The following is a description of a gene set: Mouse Gene Set: GOBP_POSITIVE_REGULATION_OF_CELL_DIFFERENTIATION studied in species Mus musculus Any process that activates or increases the frequency, rate or extent of cell differentiation., and this is the list of marker genes: Cxcr4, Sox6, Tgif2, Kat7, Mdk, Akap6 (A kinase anchor protein 6), Dcstamp, Spi1, Bmpr1b, Rhoh, Lrp8, Ppp1cc, Pla2g3, Sox12, Smarcd3, Epc1, Rab21, Hoxa5, Myocd, Gli3, Rarres2, Crabp2, Il20, Sash3, Smarca4, Acvr1b, Il6st, Ranbp3l, Tnfrsf11a, Il2, Alx1, Actr3, Smyd1, Agtr1b, Plcb1, Ninj1, Pdlim7, Twist1, Sav1, Proc, Cdkl3, Stat5b, Inhba, Nap1l1, Golga4, Nog, Sfrp4, Ep300, Fezf1, Eng, Camk2b, Jund, Isg15, Mustn1, Sh3pxd2b, Ntn1, Alox8, Epha4, Numbl, Gh, Mturn, Lck, Foxc1, Spdef, Ifitm1, Tnfrsf12a, Pithd1, Stk25, Fzd1, Clic1, Id2, Glul, Phf10 (PHD finger protein 10), Brinp1, Dlk1, Prkd1, Itpka, Eif5a, Rpl4, Hoxa11, Neurl1a, Yap1, Akt1, Il36b, Gli2, Tshz3, Il5, Il2rg, Tnf, Ctnnbip1, Tacstd2, Ccl19, Cbfb, Cebpa, Emp2, Ap3d1, Cyb5d2, Mir124a-1, Mdm2, Bcl2, Sema5a, Asxl2, Eif2b2, Tfe3, Zfp36l1, Parp2, Cth, Grip2, Otp, Macf1 (NCBI Gene Id 97195), Skil, Wdr62, Gdf7, Trp73, Prkca, Vwc2l, Cpne1, Drd2, Zfp335, Ptch2, Nedd9, Fam20c (NCBI Gene Id 97210), Apc, Msx2, Etv5, Lamb1 (laminin B1), Myrf, Tbx5, Bmal1, Zfp365, Sema4d, Asb4, Sart1, Fermt2, Ankrd54, Cysltr1, Gfi1, Cebpd, Islr2, Faim, Sirt2, Ncoa1, Ifng, Mfn2, Gper1, Map1b, Dkkl1, Kit, Prkcz, Cd1d1, Hcls1, Il2ra, Hif1an, Hap1, Brinp3, Atoh1, Sfn, Dab1, Cd36, Inpp5d (NCBI Gene Id 98312), Eeig1, Mir326, Rela, Il4i1, Dlx1, Glp1r, Kdm1a, Igf1, H2-Ea, Adig, Lilrb4a, Cldn5, Sox10, Cdh4, Tnfrsf1b, Ilk, Mtch2, Rassf10, Foxa1, L1cam, Dcx, Vim, Nrdc, Lmo3, Brinp2, Xrcc2, Il10, Lamb2, Robo1, Dmd, Tgfbr1, Rab7b, Sfrp1, Khdc3, Cd101, Il18, Mcub, Smarce1, Ihh, Smad1, Robo2, Stat1, Gjc2, Mir23a (NCBI Gene Id 387216), Tgfb1i1, Cyfip1, Tlr2, Fndc3b, Ppargc1b, Wnt3, Wnt3a, Aamdc, Ccr7, Pim1, Pa2g4 (proliferation-associated 2G4), Notch4, Sox2, Mad2l2, Prkdc, Hmgb2, Jun, Atraid, Smo, Gfi1b, Map3k13, Vnn1, Sin3a, Tmprss12, Fxr2, Pafah1b1, Foxp3, Rcor1, Gata5, Dmbt1, Arhgap32, Lhx1, Gdf3 (growth differentiation factor 3), Jade2, Kitl, Zbtb7b, Egr2, Socs5, Ikzf1, Dab2, Trf, Dpf3, Adrb1, Ceacam1, Ripk2, Brd4, Il23a, Cdh5, Atxn1, Mapk9 (NCBI Gene Id 26420), Abcb10, Metrn, Rbm4, Mapk8, Arhgef2, H2-M3, Men1 (multiple endocrine neoplasia 1), Arrb2, Adra2b, Sod2, Tlr9, Six1, Gas6, Myf5, Mtor, Gata1, Fzd3, Fbxo31, Shb (NCBI Gene Id 230126), Kdr, Ccr1, Klhl25, Egr3, Map2k2, Zfp385a, Ist1, Mesp1, Btn2a2, Pde5a, Bad, Pten, Snai2, Smad4, Cx3cl1, Cthrc1, Obsl1, Pak3, Syap1, Ezh2, Scin, Bmp4, Dbnl, Macroh2a2, Ovol2, Anxa1, Bdnf, Wnt5a, Mfn1, Klf10, Ripk1, Med1, Ahi1, Nkx2-2os, Dlx5, Olfm1, Sh3gl3 (NCBI Gene Id 20408), Tgfb2, Wwtr1, Faxdc2, Rap1a, Flt3l, Stau2, Tnfsf14, Hamp2, Ntf3, Dixdc1 (NCBI Gene Id 75356), Col1a1, Cyp26b1, Irf1, Wls (wntless WNT ligand secretion mediator), Rfx3, Ltbp3 (latent transforming growth factor beta binding protein 3), Zbtb46, Pou4f2, Dlg4, Tert, Enpp2, Prkci, Rtn4, Zc4h2, Mir100, Fxn, Gdpd2, Carmil2, Tarbp2, Cds1, Neurog1, Rb1, Uchl3, Akirin1, Mylk3, Mecp2, Xkr8, Klf5, Lrg1, Trak1 (NCBI Gene Id 67095), Cd74, Spint1, Adipoq, Cux2, Hopx, Atp11a, Lrp3, Fbn2, Plag1, Fndc5, Fgfr1, Clec7a, Acvr1, Hlx, Morf4l2, Gdnf, Egfr, Trpm4, Mef2c, Ptger4, Gata2, Efna5, Efnb2, Trpc5, Kat8, Fxr1, Crebl2, Ambra1, Smarcc1, Trem2 (NCBI Gene Id 83433), Kctd11, Pcid2, Pou4f1, Rgcc, Cul7, Ptprd, Lrp5, Trp63, Tcf15, Ppp2r3c (NCBI Gene Id 80481), Smad7, Tgfb1, Csf3, Adamts9, Tbx1, Mmd2, Sox4, Edn3, Rnd2, Nap1l2, Ccr2, Carm1, Rest, Cdx2, S100b, Gdf5, Cask, Fgf2, Pdpn, Trib1, Bmpr2, Neurod4 (NCBI Gene Id 11923), Myb, Sfrp2, Cav3, Trpc6, Numb, Xrcc6, Foxa2, Ccn3, Serpine1, Cip2a, Msr1, Kdm4c, Myod1, Dscam, Tespa1, Cmklr1, Sox8, Mapk14, Baiap2, Actl6a (NCBI Gene Id 99742), Serpinf1, Ccne1, Por, Ascl1, Slc25a4, Tox, Bin1, Actl6b, Stk3, Lig4, Insm1, Il1b, Htr2a, Sdcbp, Tescl, Gsx2, Opa1, Ltf, Hsp90aa1, Akap5, Tcf3, Thrb, Zfp219, Fos, Lamc1, Casp8, Ddx39b, Npnt, Tmsb4x, Ccn6, Hnrnpu (heterogeneous nuclear ribonucleoprotein U), Pkdcc, Prdm16, Agt, Hes1, Sp7, Zfhx3, Stk11, Amigo1, Mup20, Lin28a, Adcy10, Cux1, Dusp10, Brd2, Sh3glb1, Dbn1, Tyrobp, Ngfr, Nkx6-2, Vstm2a, Flt1, Neurog2, Runx2, Ror2, Fgfr3, Hoxd3, Ntrk3, Gja1, Xbp1 (NCBI Gene Id 52219), Adnp, Hmgb1, Pias2, Abcb1a, Mag, Slitrk1, Ffar4, Rbm24, Dicer1, Zeb1, Bloc1s5, Ptn, Notch2, Ccn5, Mapt, Nr2c2, Ccr5, Creb1, Slc6a6, Gpr68 (NCBI Gene Id 238377), Cdon, Zbtb7c, Syk, Ptgs2, Nfkbid, Dlx2, Sall1, Dag1, Car2, Caprin2, Hdac1, Xrcc4, Rin2, Gimap3, Dnmt3b, Dll3, Aspa, Piezo1, Scube2, Hoxd11, Duoxa1, Disc1, Vegfc, Bmpr1a, Fdps, Socs3, Impact, Adm, Ret, Hamp, Rnf112, Parp1, Rgs6, Actn3, Atp11c, Ache, Reln, Ncoa3, Rgs14, Foxa3, Aspm, Acvrl1, Wnt9a, Zfp609, Ankrd27, Nppc, Afdn, Zfyve27, Apoe, Mir219a-1, Nbl1, Qki, Lmna, Sult1e1 (sulfotransferase family 1E, member 1), Trip10, Kat2a, Dact1, Pik3r6, Rara, Malt1, Wnt10b, Skint1, Ngf, Lef1, Ocstamp, Bex1, Tcf4, Shoc2, Bcl6, Star, Fes (NCBI Gene Id 14159), Gsk3b, Lama2, Add1, Gdf2, Pax4, Bcl9l, Akap11, Prmt3, Epo, Mir34a, Tspo, Wif1, Il34, Il33, Slc9b2, Prkg2, Itgb3, Ephb2, Fzd4, Etv4, Gcnt2, Cebpb (NCBI Gene Id 18031), Metrnl, Dhx36, Hif1a, Ntrk2, Jag1, Atoh8, Scube3, Cdkn2b, Btg1, Slc7a5, Parp6, Clcn2, Jak2, Dnm1l, Ptprc, Nid1, Tbx20, Nkx6-1, Pin1, Lpl, Tgfbr2, Vsir, Csrp3, Itgam, Limk1, Mir124a-2, Mmp14, Timp2, Vdr, Map2k1, E2f1, Mir223, Hey1, Bmp2, Itgb1, Aurka, Ppp1r13l, Smarcc2, Nin, Tgm2 (transglutaminase 2, C polypeptide), Crb2, F11r, Ss18l1, Sox17, Rufy3, Ptpra, Snai1, Nlrp3, Cxcl9, Tnfsf9, Nkap, Xlr3b, Neurod1, Zc3h12a, Gpc1, Nr3c1, Tent5a, Cyld, Prkch, Runx1, Il21, Ap3b1 (adaptor-related protein complex 3, beta 1 subunit), Sox9, Kat5 (K(lysine) acetyltransferase 5), Trpv2, Arid1a, Grm5, Foxn1, Nkx2-5, Hsf1, Btc, Dkk1, Smap1, Boc, Socs2, Ell3, Heyl, Serpine2, Stat5a, Csf1r, Fbxo5, Shank3, Zbtb1, Prpf19, Lrp2, Ets1, Ifi204, H2-Aa, Gdf10, Ddr2, Nell1, Pparg, Tgif1, Fezf2, Bmp7, Wnt2 (wingless-type MMTV integration site family, member 2), Sox5, Lpar3, Cd34, Chodl, Lrp1, Srrt, Nme2 (NCBI Gene Id 18103), Upf3b (NCBI Gene Id 68134), Shox2, Plxnb2, Clcf1, Prl2c2, Synj1, Myf6, Hspa1b, Csf1, Dubr (NCBI Gene Id 68190), Spen, Cd27, Smad2, Actb, Dpf1, Zbtb16, Ccdc3, Tesc, Sirt6, Dmrta2, Slc30a1, Zfp36, Zhx3, Igfbp3, Lrrc8a, Vwc2, Vezf1, Lama1, Eif4g2, Ada, Plxnd1, Srf, Brd7, Fmr1, Nr5a2, Id4, Csf2, Commd5, Notch1, Ace, Ect2, Cd83, Evi2, Bag1, Ager, Xrcc5 (X-ray repair complementing defective repair in Chinese hamster cells 5), Ctnnb1, Nek5, Noct, Cftr, Ar, Itpkb, Pbrm1, Ccl3, Tnik, Actr2, Pwp1, H2-DMa, Tenm4, Irx3, Smad3, Bend6, Il15, Agtr1a, Sult2b1, Mapk8ip3, Tnfsf4, Nkx2-2, Ccl5, Neurog3, Cdkl5, Smarcd2, Maml1, Bhlhb9, Twf2, Ppp3ca, Cd40lg, Bcl11a, Ptprz1, Shh (NCBI Gene Id 20423), Il4ra, Map3k5, Olfm2, Pde3a, Nptn, Marcks, Adamts20, Gdpd5, Acvr2a, Bloc1s6, Mir124a-3, Nf2, Fbxw8, Ipo7 (importin 7), Clu (NCBI Gene Id 28201), Pck1, Suco, Megf8, Cd4, Hax1, Rheb, Brd1, Wdfy2 (NCBI Gene Id 268752), Tbc1d24, Uts2, Mir137, Hoxb4, Foxo3, Cd24a, Kras, Mamstr, Smad9, Smarcd1, Ptch1, Mme, Sgk1, Nrg1, Mpl, Tiam1, Acvr2b, Pnp, Tcf7l2, Vegfa, Evi2b, Ptk2, Hdac6, Map6, Anapc2, Il4, Isl1, Pias1, Kalrn, Lta, Nefl, Zfp488, Fn1, Cxcl12, Smarca2, Rasgrp1, Mir210, Rras, Grip1, Sema7a, Macroh2a1 (NCBI Gene Id 26914), Zap70, Gdi1, Bambi, Cd46, Gnas, Tph1, Ripor2, Met, Ccn1, Tnfsf11, Tcf12, Fam210b, Mir675, Nrp1, Nfkbiz, Nudt21, Medag, Pik3r1, Acin1, Nr2e1, Hmg20b, Rreb1, Rptor, Snap91, Il1rapl1 (NCBI Gene Id 76162), Zeb2, Phox2b, Tle6, Fgf18, Napepld, Runx3, Braf, Eif4g1, Hsp90ab1, Edn1, Ramp2, Glipr2, Mir3960, Dct, Pkp1, Htr2c, Bnip2, Stat3, S1pr2 (sphingosine-1-phosphate receptor 2), Adam7, Nr6a1, Mir219a-2, Rapgef2, Lif, Ptprf, Pax8, Fadd (Fas associated via death domain), Junb, Picalm, Pax6, Axl, Zmiz1, Prom1, Ctf2, Tiam2, Hdac2, Lgals9, Cx3cr1, Tmem64, Sox13, Zfp703, Ccn2, Nckap1l, Shtn1, Gdf6, Ccl8 (C-C motif chemokine ligand 8), Pin1rt1, Ddrgk1, Il12b, Gimap5 (NCBI Gene Id 319541), Axin2, Camk1, Pak1, Myo5b, Man2a1, Kdf1, Neurod2 (NCBI Gene Id 18013), Tgfb3, Wnt4, Ccl9, Ccr1l1, Smurf1, Rhoa, Tmem119, Frzb, Myc, Il1rl2, Snw1, Bmp6, Bmp10, Smad5, Sirt1, Eef2k, Olig2, Prmt1, Arid2, Prmt5, Tal1, Plxnb1, Il15ra, Spag9, Il12a, Stk4, Etv2, Dnai3, Oprm1, Foxj1, Socs1, Loxl2 (lysyl oxidase-like 2), Lyn, Ndel1, Crxos, Apob, Mmd, Lilrb4b, Golga2, Prox1, Il3, Efemp2, App, Adam8, Numa1, Il7r, Il17a, Wnt5b, Gfap, Ccn4, Ufl1, Tmem100, Gata3, Cd276 (NCBI Gene Id 266672), Rag1, Mecom, Il6, Pcp4, Sox11, Pla2g5, Wnt7b, Gprc5b, Thpo, Pax2, Plxnb3, Plxnc1, Nfkb1, Lmod3, Trim32, Neu2, Cyp27b1, Caprin1, Traf6, Il7, Setd3, Smarcb1, Myog (NCBI Gene Id 17928), Foxg1, Cyp51, Serpinf2, Adra2c, Kdm4a, Bnc1, Znhit1